Given this list of marker genes SOS2, S100A12, SUMO1, ADNP2, LILRA3, DDX46, KLF11, PSENEN, H1-0, SEPTIN11, USP15, CCND3, PSMD12, EMD, IDH3G, SYNJ1, USP4, DDIT3, NANS, MED6, ARHGEF11, POLR2G, RCOR1, IL18RAP, SATB1, DOCK10, RPL24, VIPR1, VPS11, MDM4, TNS1 (NCBI Gene Id 7145), CPEB3, ANP32B, ORMDL2, SDC4, CORO7, SLC35A1, IPPK, NSUN5, IL1R2 (NCBI Gene Id 7850), ATP5MJ (ATP synthase membrane subunit j), RAB2A, UBE2K, THUMPD1, ANXA5, TNFRSF10C, CD59, RGL2 (ral guanine nucleotide dissociation stimulator like 2), HSD17B7, DHRS9, NQO2, TXNL4A, MTF2, HSPBAP1, USP32P2, UBE4A, MYOC, UQCRC2, MYOT, HNRNPA0, CLDN6, CAMLG, GLA, WDR45B, TIA1, PRC1, INTS6, PEF1, ST13, CORO1A (NCBI Gene Id 11151), TMEM268, USP22, TCFL5, GUK1, RBBP7, SAP18, CNN2 (calponin 2), GALNT1, RSBN1, IFIT5, STMN1, BAZ2B (NCBI Gene Id 29994), PIGG, DHX29, KTN1, NOTCH1, LARS1, CRY1, IKZF5, CHUK (NCBI Gene Id 1147), ANAPC13, DPP6, APH1A, YTHDC2, NPY1R, WDR47, PSME4, CA4 (NCBI Gene Id 762), DDX54, YIPF1, ANO10, PPP1CA, OSGIN2 (oxidative stress induced growth inhibitor family member 2), MBD2, MGST2 (NCBI Gene Id 4258), SHFL, COMMD8, POMP, REPIN1, DEF8, SMARCD2, CYC1, KCNA4, DHX40 (DEAH-box helicase 40), YIPF4, HSPE1 (heat shock protein family E (Hsp10) member 1), CEP68, SAA4, GNPAT, CLDN8, RAB32, PLP2, TLR5, BPESC1, VDAC3, PKN2, HAX1, LRFN4, SS18L1, ZCCHC8, MYL3, CD302, FLI1, GLRX3, GABRB1, PHF3, ZFP36L1, PSMA2, HIGD1A (HIG1 hypoxia inducible domain family member 1A), RNF4, SENP6, ODR4, AGO2, WNT5A, PTEN (phosphatase and tensin homolog), SEL1L, RPL6, RTL8C, NFE2, ATF3, KDM3B, DNAJB14 (DnaJ heat shock protein family (Hsp40) member B14), MARF1, AGPAT1, SLC25A24, FAAP24, AKAP17A, IFNA14, UCHL5, JMJD1C, CD52, RLF, SH3BGRL, FAM13B, PRMT2, MARCHF3, KHDC1L, PSMB2, GRIK2, NDUFA4, INTS8, BPTF, SCAMP1, MDH1, ZNF140, SLC2A9, ITPKB, ITGA2, GABPB1-IT1, CDS2, AP5Z1, SFN, RASL12, MRPL33, SLC30A1, TDG, NFATC1, STAG1, CALCOCO1, NIBAN1, ARHGEF40, NUP133, CASP7, MGAM, VPS54, DESI2, PARP8, HSPA13, P2RY14, here is a description of the gene set: from publication Wright HJ, Chapple IL, Matthews JB, Cooper PR (PMID 20663022) species: Homo sapiens Human Gene Set: GSE20151_CTRL_VS_FUSOBACT_NUCLEATUM_NEUTROPHIL_DN Genes down-regulated in comparison of contols neutrophils versus those infected with a bacterium (F. nucleatum). Neutrophils are known to be stimulated by different periodontal bacteria to produce reactive oxygen species and cytokines. It is inportant to investigate the gene changes made by bacteria of importance, of which, for periodontal disease, fusobaterium nucleatum is one. we used microarrays to investigate gene experssion changes in peripheral blood neutrophils werwhich e stimulated with or with out Fusobacterium Nucleatum (10953).